The following is a description of a gene set: Cardiomyocyte signaling converging on titin studied in species Homo sapiens Human Gene Set: WP_CARDIOMYOCYTE_SIGNALING_CONVERGING_ON_TITIN, and this is the list of marker genes: FHL1, TRIM55 (NCBI Gene Id 84675), MAPK1, GUCY1B1, GUCD1, PRKG2, CAMK2A, MAP2K2, TTN, SRF, CRYAB, PRKCA, NBR1, NUP62, PRKAR1A, MYPN, ADRB1, MAP2K1, PRKACA, ANKRD1, ANKRD2, PLCZ1, PRKACB, TRIM63, RAF1, ANKRD23, NPR1, FHL2, ADRB2, PRKACG, TCAP, CSRP3, MDM2